Given this list of marker genes PNPLA3, PISD, FITM1, LDAF1, AUP1, ZFYVE1, PRKAA2, CIDEB, SMIM22, CDS2, PPID, SQLE, PLIN5, BSCL2, PRKAA1, CIDEA, FAF2, PLIN3, FITM2, PLIN2, TSPO2, CDS1, DDHD2, CHKA, CIDEC, KAT5, NEGR1, PPIA, PTGFRN, TBC1D20, RAB18, MOSPD2, LDAH, PNPLA2, RNF213, SPART, RAB3GAP1, CLSTN3, PLA2G4C, here is a description of the gene set: A process that is carried out at the cellular level which results in the assembly, arrangement of constituent parts, or disassembly of a lipid particle. Human Gene Set: GOBP_LIPID_DROPLET_ORGANIZATION studied in species Homo sapiens